Given this list of marker genes ELL2, MYBPC3 (myosin binding protein C3), RASGRP4, CDC42EP3, CSRP2, CCL5, MAP9, IL12A, DUSP1, CCR10, GPR88, CDC25B, RNF133, B4GALT6, DUSP3, GALNT3, GM2A, GPD1L, TNFRSF13B, SOX14, HIP1, ADAM15, SEC24D, IKZF2, ZMAT4, FAM185A, SERPINA6, ITPRID2, PLEKHA2, ARNT2, RBL2, CRYBA4, ZYG11A, ZSWIM5, PKHD1L1, COBL, NBEA, CASP1, OVOL2, PLCZ1, KIFC1, STBD1 (NCBI Gene Id 8987), CFAP206, CTSH, NIPA2, EPCAM, CCL22, ADAMTS2, DYNLT5, CA5B, UBL3, RAP1GAP2, CYSLTR1, CUTC, TRPC1, SLC25A19, CCL13, ATXN7, LAMTOR3, SOD3, CCR5, SAP30, NDRG4, DHRS13, TEX47, IRF5, DAND5, PLEKHG3, SUN1, DYDC1, RAPH1, GPR15, MBD2, APPL2, LMNB1, NUDCD2, SLC11A1, HLF, IL18, PBX3, TNFAIP8 (TNF alpha induced protein 8), CCDC25, KHDRBS2, TEKT3, VCL, APH1B, RPS6KA5, RMDN2 (NCBI Gene Id 151393), ATXN1, NXPE4, NFATC4, RPUSD3, CBFB, ZHX3, HBP1, SNAPC5, BRWD1, M6PR, ZBTB42, CXCR6, CIMIP5, CD109, CHIC1, RASSF4, DIRAS2, PIGZ, LRIT1, PLS3 (plastin 3), GPAT3, CASP4, CXXC4, CCR2, ZNF296, RELL1, STMN3, TBC1D16, LRRN3, SYTL2, ONECUT3 (one cut homeobox 3), REXO5, UEVLD, TF, ANKRD29, SANBR, PRR13, CHSY1, TSPAN17, COL7A1, PIK3CA, DPYSL5, PPP1R3B, CIITA, LDOC1, CCR1, NXNL2, DNMT3L, LGMN, PDZD11, CASS4, TSHZ3, ABCB10, SETD4, NPNT, SCRT2, RASGEF1C, SLC17A5, CMKLR1, RSPO2, LRP11, SDCCAG8, REP15, FUT8, BCO2, KIF13B, DCTN5, SOX15, TMC8, PNPLA1, S100A6, C9orf50, FAM171B, CRIP2, DLK1, ASCL3, CYP2S1, RAB36, KAZN, FBXO27, MOCOS, TMEM37, RNASE4, CD33, RAB39B, HPSE, CDC42BPB, SMPD3, CAMK2N1, BSPRY, MED7, OSBPL3, COBLL1, FIRRE, PTPRJ, NRK, FGL2, ERN1, DIP2A, SEPTIN10, METRNL, CEP112, INO80C, PHACTR4, CPM, CYB561 (cytochrome b561), MUC1, ALCAM, KRT82, H1-0, GNAQ, HADH, here is a description of the gene set: Genes down-regulated in comparison of TregCD103+Klrg1- versus TregCD103+Klrg1+ (see Table 1S in the paper for details). Human Gene Set: GSE20366_CD103_POS_VS_CD103_KLRG1_DP_TREG_DN Regulatory T (Treg) cells that express the FoxP3 transcription factor are essential for lymphoid homeostasis and immune tolerance to self. Other non-immunological functions of Treg cells, such as controlling metabolic function in adipose tissue, are also emerging. Treg cells originate primarily in the thymus, but can also be elicited from conventional T cells by in vivo exposure to low-dose antigen or homeostatic expansion, or by activation in the presence of TGFβ in vitro. Treg cells are characterized by a distinct transcriptional signature controlled in part, but not solely, by FoxP3. For a better perspective on transcriptional control in Treg cells, we compared gene expression profiles of a broad panel of Treg cells from various origins or anatomical locations. Treg cells generated by different means form different sub-phenotypes identifiable by particular combinations of transcripts, none of which fully encompass the entire Treg signature. Molecules involved in Treg effector function, chemokine receptors, and the transcription factors that control them are differentially represented in these subphenotypes. Treg cells from the gut proved dissimilar to cells elicited by exposure to TGFβ, but instead they resembled a CD103+Klrg1+ subphenotype preferentially generated in response to lymphopenia. from publication Feuerer M, Hill JA, Kretschmer K, von Boehmer H, Mathis D, Benoist C (PMID 20231436) species: Homo sapiens